The following is a description of a gene set: Mouse Gene Set: GOMF_MODIFIED_AMINO_ACID_TRANSMEMBRANE_TRANSPORTER_ACTIVITY Enables the transfer of modified amino acids from one side of a membrane to the other. studied in species Mus musculus, and this is the list of marker genes: Abcc4, Slc22a21, Pdpn, Slc25a20, Slc7a9, Slc25a13, Abcc5 (ATP-binding cassette, sub-family C member 5), Slc6a20a (NCBI Gene Id 210451), Slc22a15, Slc46a1, Slc25a32, Slc25a26, Ctns, Slc6a13, Slc22a16, Slc22a1, Slc25a12, Slc13a3, Slc25a40, Slc6a8, Abcc1, Slc25a39, Gja1, Slc22a4 (NCBI Gene Id 56507), Slc16a12, Slc5a6, Slc22a5, Slc1a4, Slc6a14, Slc7a11 (NCBI Gene Id 99638), Slc19a1, Slc19a3, Slc16a9